Given this list of marker genes STOX1, DDIT3, ATM, ATG5, DNAJA1, PARK7, here is a description of the gene set: Any process that results in a change in state or activity of a cell (in terms of movement, secretion, enzyme production, gene expression, etc.) as a result of a nitrosative stress stimulus. Nitrosative stress is a state often resulting from exposure to high levels of nitric oxide (NO) or the highly reactive oxidant peroxynitrite, which is produced following interaction of NO with superoxide anions. Human Gene Set: GOBP_CELLULAR_RESPONSE_TO_NITROSATIVE_STRESS species: Homo sapiens